Given this list of marker genes CDKN1A, ZNF385A, PCBP4 (poly(rC) binding protein 4), TP53, here is a description of the gene set: Both p53-independent and p53-dependent mechanisms of induction of p21 mRNA have been demonstrated. p21 is transcriptionally activated by p53 after DNA damage (el-Deiry et al., 1993). Reactome Pathway: Transcriptional  activation of  cell cycle inhibitor p21 studied in species Homo sapiens part of: Transcriptional activation of p53 responsive genes  